The following is a description of a gene set: Any process that modulates the frequency, rate or extent of flagellated sperm motility. Human Gene Set: GOBP_REGULATION_OF_FLAGELLATED_SPERM_MOTILITY studied in species Homo sapiens, and this is the list of marker genes: TACR3, TACR1, TAC4 (tachykinin precursor 4), SEMG2, CFAP69, TPPP2, TAC1 (tachykinin precursor 1), RNASE10, EPPIN, CFAP206, IRGC, SEMG1, TACR2, IQCF1, PGAM4, CLXN, DEFB1, KIF9, TAC3, ADAM7, CCR6 (NCBI Gene Id 1235), PRDM14, TEX101